The following is a description of a gene set: Supernumerary digits located at the ulnar side of the hand (that is, on the side with the fifth finger). Postaxial hand polydactyly species: Homo sapiens Human Gene Set: HP_POSTAXIAL_HAND_POLYDACTYLY, and this is the list of marker genes: BBS12, CCDC28B, MBTPS2 (NCBI Gene Id 51360), RAB23, CD96, PRKACB, WNT7A, DYNC2LI1, TCTN3, MKKS, OTUD5, MAX, DYNC2I1, FGFR2 (NCBI Gene Id 2263), SC5D, SCNM1, ZNF141, B9D1, KIF7, PDE6D, RPGRIP1L, GPC4, WDR19, RAB34, DDX59, NEK1, TMEM216, GPC3, KIAA0825 (NCBI Gene Id 401202), CCND2, MKS1, TMEM107, ARL6, C2CD3, CPLANE1, TMCO1, LMBR1, CEP120, BMPR1B, TTC21B, ALX3, AKT3, INPP5E (inositol polyphosphate-5-phosphatase E), B9D2, SUFU, TMEM67, DHCR7, PORCN, MEGF8, TCTN1, TBX5, EVC2, CEP290, FLNA, PIK3R2, IFT172, DYNLT2B, SETBP1, HYLS1, LBR, CSPP1, IFT140, DYNC2I2, TMEM231, TMEM237, WDR35, IQCE (NCBI Gene Id 54774), TCTN2, BBS9, LZTFL1, TXNDC15, DYNC2H1 (NCBI Gene Id 79659), GLI3, EVC, CC2D2A, SMOC1, TGFBR1 (transforming growth factor beta receptor 1), HOXA13 (homeobox A13), BBS1, CFAP418, ARMC9, GLI2, RPGRIP1, WDPCP, SMO, KIAA0753, BHLHA9, CIBAR1, BBS2, OFD1 (NCBI Gene Id 8481), TBX3, IFT80, PLAA, GDF5